Given this list of marker genes NFE2L1, MSC, RBM5, JUNB, HPS5, TAP1, NEU1, ATP10D, EIF4EBP1, KIFC3, STAT6, ITGAX, BAG2, ATP6V0A1, MMD, POLR1C, H2BC5, BCL2L2, TPP1, LEPR, GUCY1A1, HSPA13, PLOD1, BCAT1, RELB, CLK2, AHSA1, CHERP, TBL1X, UBE2B, ID3, MAFF, CEBPG, TSC22D3, TLE4, CTSA, PFDN5, ATP6V1G1, TSC1, SPRR3, PLIN2, NEAT1, ATP6V1C1, BCAS2, HNRNPAB, SH2D3C, ME1, HYAL2, IL10RA, ISYNA1, DLC1, TANK, MED14, SOD1, STK17A, TAOK3, DNAJA1, NPM1, IGF2R, DNTTIP2, MT3, ASB3, ADAM17, TMSB15B, FJX1, SCRN3, DNAJB4, ATF3, RPL27, UBE2H, PRKCA, FXR1, GTF3C3, SH2B1, TUBGCP3, PLAAT3, ZMYND8, APBA2, HMBS, MT1X, CNTRL, PEX11B, MARS1, HSPA1L, HIBCH, FHL2 (NCBI Gene Id 2274), CHD2, ASNS (asparagine synthetase (glutamine-hydrolyzing)), BMAL1, MLLT11, SLC22A1, RALGDS, PCK1, MAN1A2, BCL3, IARS1, TRIP13, ZFAND5, ZNF43, MT1G, STK10, KDM2A, DDIT3, TMF1, ETS2, RIT1, FOXO3, OGT, DAZAP2, ZNF184, TNFRSF10B, MT1B, GOLGB1, UBXN8, RPUSD2, DAG1, ZNF85, CLEC2B, SPARCL1, SRPK2, RNF115, RRAGA, E2F6, ST3GAL5, CLK1, GK2, PIK3R4, TFE3, CIT, CCT8, MR1, BMP2K, RUNX3, TULP4, AKAP1, MED16, HSPA4L, CDK6, ZNF254, TOP3A, ATP6V0E1, N4BP2L2, DNAJB5, HEXA, SIAH2, NKTR, PSPHP1, ACAP2, VEGFA, CDC42EP3, KDM6A, ZSCAN26, B3GNT6, FUT4, GRN, ZFX, IL6ST, HSPA4, PRNP, CTDSP1, MAFG, PLTP, NFE2L2, PDS5B, RCC1, NAALAD2, SERPINH1, PAXIP1, ATP2C1, DYRK1A, MT1L, ATP6V0D1, CARS1, GARS1, CEBPB, KLF12 (NCBI Gene Id 82238), INTS6 (NCBI Gene Id 26512), STC2, MT1F, LYN, DNAJB6, UPP1, IRAG2, KCNF1, MT1E, HSPA9, RPS6KC1, CDC14A, GLA, AGXT, HSPE1, REV3L, SLC43A1, EIF2S2, LYZ, EXT1, ST13, LAMTOR3, GTF2H1, CPEB4 (cytoplasmic polyadenylation element binding protein 4), MAPK7, ADNP, CCPG1, CNPY2, CTH, AP4B1, SLC7A5, TIMM17A, WARS1, SLC1A4, RAD51AP1, IGFBP6, MT1H, PTPRB, TNKS (NCBI Gene Id 8658), ESRRA, ANLN, ARIH1, ZNF24, here is a description of the gene set: Genes discriminating responses to sodium arsenite from other stresses. Human Gene Set: AMUNDSON_RESPONSE_TO_ARSENITE from publication Amundson SA, Do KT, Vinikoor L, Koch-Paiz CA, Bittner ML, Trent JM, Meltzer P, Fornace AJ Jr (PMID 15824734) Gene expression responses of human cell lines exposed to a diverse set of stress agents were compared by cDNA microarray hybridization. The B-lymphoblastoid cell line TK6 (p53 wild-type) and its p53-null derivative, NH32, were treated in parallel to facilitate investigation of p53-dependent responses. RNA was extracted 4 h after the beginning of treatment when no notable decrease in cell viability was evident in the cultures. Gene expression signatures were defined that discriminated between four broad general mechanisms of stress agents: Non-DNA-damaging stresses (heat shock, osmotic shock, and 12-O-tetradecanoylphorbol 13-acetate), agents causing mainly oxidative stress (arsenite and hydrogen peroxide), ionizing radiations (neutron and gamma-ray exposures), and other DNA-damaging agents (ultraviolet radiation, methyl methanesulfonate, adriamycin, camptothecin, and cis-Platinum(II)diammine dichloride (cisplatin)). Within this data set, non-DNA-damaging stresses could be discriminated from all DNA-damaging stresses, and profiles for individual agents were also defined. While DNA-damaging stresses showed a strong p53-dependent element in their responses, no discernible p53-dependent responses were triggered by the non-DNA-damaging stresses. A set of genes did exhibit a robust p53-dependent pattern of induction in response to all nine DNA-damaging agents, however. studied in species Homo sapiens